Given this list of marker genes MYC, LEF1, TLE3, TLE5 (NCBI Gene Id 166), CTBP2 (C-terminal binding protein 2), TLE2, TCF7L1, HDAC1, TCF7, CTBP1, TCF7L2, TLE1, AXIN2, TLE4, here is a description of the gene set: Human Gene Set: REACTOME_REPRESSION_OF_WNT_TARGET_GENES Repression of WNT target genes studied in species Homo sapiens